Given this list of marker genes ARR3, SAG, SPTBN5, IFT20, PRCD, here is a description of the gene set: Human Gene Set: GOMF_OPSIN_BINDING species: Homo sapiens Binding to an opsin, any of a group of hydrophobic, integral membrane glycoproteins located primarily in the disc membrane of rods or cones, involved in photoreception.